Given this list of marker genes LILRA4, ATP1B2, WNT10B, EFNA3, GRM4, RREB1, SLC12A4, NCKIPSD (NCBI Gene Id 51517), NPPA, MC2R, ZNF157, PSG1, LY6G6C, ADCYAP1, KAT7, VAMP1, CEACAM4, BUD23, TRIM58, TNP1, IGHMBP2, PFKFB2, AIF1, IGSF9B, POU4F1, PRPH, PCBP3, here is a description of the gene set: Human Gene Set: CAR_MYST2 studied in species Homo sapiens Neighborhood of MYST2 MYST histone acetyltransferase 2 in the CAR expression compendium Neighborhood of MYST2